Given this list of marker genes Cdkn1a, Uimc1, Mus81, Dtl, Rad9b, Ccnd1, Map3k20, Foxn3, Atf2, Brsk1, Fzr1, Babam2, Setmar (SET domain without mariner transposase fusion), Plk1, D7Ertd443e, Tipin, Orc1, Prkdc, Mbtps2, Creb3l1, Clspn, Atm, Mre11a, Rad9a, Rps27l, Dgkz, Ptprv, Nbn, Trp53, Zfp830, Mbd4, Stk33, Brca1, Nae1, Cdc6, Mbtps1, Taok3, Eme2, Fancd2, Ppp1r10, Abraxas1 (NCBI Gene Id 71440), Trex1, Chek2, Ccng1, Trim39, Cdk1 (cyclin dependent kinase 1), Wac (NCBI Gene Id 76331), Xpc, Fbxo31, Brcc3dc, Cdc14b, Topbp1, Rpa2, Hus1, Nek11, Hus1b, Ticrr, Taok1, Sde2, Msh2, Rint1, Taok2, Ier3, Cdk5rap3, Syf2, Babam1, Chek1, Rad17, Gigyf2, Mrnip, Blm, Donson, Eme1, Foxo4, Nop53 (NCBI Gene Id 98700), Brcc3, Rfwd3, here is a description of the gene set: species: Mus musculus Mouse Gene Set: GOBP_MITOTIC_DNA_INTEGRITY_CHECKPOINT_SIGNALING A signaling process that controls cell cycle progression in response to changes in DNA structure by monitoring the integrity of the DNA during mitosis. The DNA integrity checkpoint begins with detection of DNA damage, defects in DNA structure or DNA replication, and ends with signal transduction.